The following is a description of a gene set: species: Homo sapiens Well-demarcated area(s) of partial or complete depigmentation in the fundus, reflecting atrophy of the retinal pigment epithelium with associated retinal photoreceptor loss. Human Gene Set: HP_RETINAL_ATROPHY Retinal atrophy, and this is the list of marker genes: MAK, ARSG, EPG5, ARL6, CNGB1, BBS5, DHDDS, BBS1, AIPL1, CEP78, CFAP418, ZNF408, ALMS1, TUB, NMNAT1, CFI, ARHGEF18, DRAM2, NR2E3, APOE, MERTK, CA2 (NCBI Gene Id 760), RBP4, OPN1MW, ATF6, SH3BP2, PDE6B, PRPF8, IFT88, PROM1, PITPNM3, ALDH3A2, PCARE, MIR204, RIMS1, ARL3, CFH, NEK2, TTC8, CLRN1, OFD1, CDH3, CYP4V2, HGSNAT, IFT140, RDH12, PLK4, CACNA2D4, GUCA1B, IFT172, CFAP410, PNPLA6, USH2A, SAMD7, POMT2, TULP1, ERCC6, VCAN, HMCN1, TNFRSF11B, C1QTNF5, PDE6A, RDH11, ASXL1, RPGR, FKRP, STUB1, KCNV2, LZTFL1, IDH3A, GBA1, EFEMP1, BBS2, IFT43, LCA5, POMGNT1, RPE65, CRB1, BEST1, NRL, PDE6G, PRPF31, CDHR1, KIZ, TIMP3 (TIMP metallopeptidase inhibitor 3), RDH5, FSCN2, PRCD, IMPDH1, RP1, SNRNP200, RP9, TLCD3B, INPP5E, SLC6A6, HLA-A, SCAPER, POC1B, ZNF513, KLHL7, CNGA3, RAX2, ADAM9, SAG, CFHR3, RS1, CRX, FKTN, TOPORS, MAPKAPK3, RPGRIP1, CC2D2A, RP2, SLC7A14, MFRP, AHI1 (NCBI Gene Id 54806), PCYT1A, CTSD, CACNA1F, OPN1LW, AHR, RGR, RHO, CERKL, GUCY2D, YARS1, CA4, PRPH2, SPATA7, SEMA4A, POMT1, PDE6C, GUCA1A, ABCA4, CFHR1, HK1, GNAT2, IMPG1, RP1L1, TTLL5, ELOVL4, AGBL5, DHX38, CNGB3, RAB28, SLC24A1, FAM161A, WDR19, LARGE1, CNGA1, ROM1, RLBP1, IMPG2, IDH3B, EYS, PRPF6, ERCC8 (ERCC excision repair 8, CSA ubiquitin ligase complex subunit), REEP6, SIX6, RBP3, ARL2BP, PRPF3, PDE6H, PRPF4, TRNT1, LAMA1, UNC119, LRAT, KIAA1549, CNNM4